Given this list of marker genes Kdm5b, Slc12a2, Ccl11, Mst1, Robo1, Slit2, Csf1, here is a description of the gene set: Mouse Gene Set: GOBP_MAMMARY_DUCT_TERMINAL_END_BUD_GROWTH species: Mus musculus The morphogenetic growth of the large, club-shaped terminal end of a mammary gland duct during prepubertal growth and during puberty.